Given this list of marker genes MCM6, IDE, HLA-DQB1, TOP2A, MCM10, CKS1B, KIN, ZNF358, TRIP13, COIL, SSX2IP, RRM1, RPA1, MIS18BP1, CENPE, KIF23, DLGAP5, BRCA2, HOXC5, KIFC1, CDC45, CBX1, CIT, PPP1CA, PCLAF, PIH1D1, SGO1, CDKN2C, NUDC, PLK4, VPS72, INCENP, NEK2, CENPA, TUBB, UBE2C, WDHD1, TUBA1B (tubulin alpha 1b), MMP14, CDKN1A, LDHA, PSMC3, NEDD4, RFC3, GSPT1, RAD54L, CKAP5, CDCA5, HAUS6, H2AC8, MYEF2, ENO1, CASP3, CIP2A, ANP32E, KIF4A, MTHFD2, ANP32A, RRM2, ACY1, NUCKS1 (nuclear casein kinase and cyclin dependent kinase substrate 1), TUBB4B, PRC1, SNX2, RAD51, ANLN, ITGB7, NCAPH2, SPDL1, ABR, CAMP, FAM111A, HLA-DRB1, CBX5, RFC5, HELLS, E2F8 (NCBI Gene Id 79733), EIF2AK2, TTK, CDK1, ANP32B, HMGB2, BUB1, AZIN1, SLC29A1, NT5DC2, HMGB3, SMC4, NASP, KIF22, RAMP1, HJURP, AARS1, DDX19A, CHAF1B, CTC1, CCNB2, CCNE1, MELK, GSN (gelsolin), KPNA2, POLA1, IPO5, ACTN4, CDCA3, SMC2, CDC20, NUSAP1, DCTPP1, CDC25C, CKS2, MYH11, FLII, AURKA, ECT2, CCNB1, STIM1, TK1, TMPO (NCBI Gene Id 7112), PPP2CA, H2AX (NCBI Gene Id 3014), RBL1, DNA2, STMN1, LIG1, NCAPH, GPHN, FEN1, CCNA2, CDKN3, TRIM46, TUBA3D, IL4, TUBB3, DBF4, HTT, CRIP2, XPO1, MKI67, AURKB, PCK2, UBE2T, KIF20A, ARL1, HES1, CENPL, UBE2S (NCBI Gene Id 27338), KIF2C, DNMT1, TUBA1A, RACGAP1, JADE1, here is a description of the gene set: from publication Hoffmann R, Seidl T, Neeb M, Rolink A, Melchers F (PMID 11779835) Genes up-regulated during differentiation from large pre-BII to small pre-BII lymphocyte. species: Mus musculus Human Gene Set: HOFFMANN_LARGE_TO_SMALL_PRE_BII_LYMPHOCYTE_UP Gene expression profiles of five consecutive stages of mouse B cell development were generated with high-density oligonucleotide arrays from as few as 2 x 10(4) ex vivo isolated and flow-cytometrically purified cells. Between 2.8% and 6.8% of all genes change on differentiation from one cellular stage to the next by at least twofold. The entire pathway involves differential expression of 10.7% of all genes. Previously known expression patterns of genes (like surrogate light chain, RAG-1/2, MHC class II, mel-14 antigen) are confirmed. The gene expression patterns of the proliferating pre-BI and large pre-BII cells on the one hand, and the resting immature and mature B cells on the other hand, are most similar to each other. Small pre-BII cells display a pattern that is transitional between these two groups. Most of the genes expressed in early precursors are involved in general processes, like protein folding or cell cycle regulation, whereas more mature precursors express genes involved in more specific molecular programs (cell surface receptors, secreted factors, and adhesion molecules, among others). Between 19 and genes share a given expression pattern. Combining knowledge about gene function and expression pattern allows identification of novel candidate genes potentially involved in self-maintenance of pre-BI cells, allelic exclusion and pre-B cell receptor signaling in large pre BII cells, cell-cycle arrest of small pre-BII cells, propensity toward apoptosis or anergization in immature B cells, propensity toward cell division and activation in mature B cells, and stage-specific interactions with stromal cells in the bone marrow.